Given this list of marker genes PRPS1, PRPS1L1, PRPS2, here is a description of the gene set: 5-Phospho-alpha-D-ribose 1-diphosphate (PRPP) is a key intermediate in both the de novo and salvage pathways of purine and pyrimidine synthesis. PRPP and the enzymatic activity responsible for its synthesis were first described by Kornberg et al. (1955). The enzyme, phosphoribosyl pyrophosphate synthetase 1, has been purified from human erythrocytes and characterized biochemically. The purified enzyme readily forms multimers; its smallest active form appears to be a dimer and for simplicity it is annotated as a dimer here. It specifically catalyzes the transfer of pyrophosphate from ATP or dATP to D-ribose 5-phosphate, and has an absolute requirement for Mg++ and orthophosphate. The significance of the reaction with dATP in vivo is unclear, as the concentration of cytosolic dATP is normally much lower than that of ATP. The importance of this enzyme for purine synthesis in vivo has been established by demonstrating excess phosphoribosyl pyrophosphate synthetase activity, correlated with elevated enzyme levels or altered enzyme properties, in individuals whose rates of uric acid production are constitutively abnormally high.<P>Molecular cloning studies have revealed the existence of two additional genes that encode phosphoribosyl pyrophosphate synthetase-like proteins, one widely expressed (phosphoribosyl pyrophosphate synthetase 2) and one whose expression appears to be confined to the testis (phosphoribosyl pyrophosphate synthetase 1-like 1). Neither of these proteins has been purified and characterized enzymatically, nor have variations in the abundance or sequence of either protein been associated with alterations in human nucleotide metabolism, so their dimerization and ability to catalyze the synthesis of PRPP from D-ribose 5-phosphate are inferred here on the basis of their predicted amino acid sequence similarity to phosphoribosyl pyrophosphate synthetase 1. studied in species Homo sapiens part of: Pentose phosphate pathway Reactome Pathway: 5-Phosphoribose 1-diphosphate biosynthesis